The following is a description of a gene set: Any process that modulates the frequency, rate or extent of receptor clustering. studied in species Homo sapiens Human Gene Set: GOBP_REGULATION_OF_RECEPTOR_CLUSTERING, and this is the list of marker genes: SHISA6, RAC1, TNFAIP6, SLC7A11, SHISA7, FZD9, DOK7, CRK, GRIPAP1, MESD (NCBI Gene Id 23184), FRRS1L, ZDHHC2, SSH1, CRKL, CD81, LRP4, FNTA, FARP1, GSN